The following is a description of a gene set: Genes having at least one occurrence of the highly conserved motif M139 AAAYWAACM in the regions spanning 4 kb centered on their transcription starting sites. This matches the FOXJ1 transcription factor binding site V$HFH4_01 (v7.4 TRANSFAC). Human Gene Set: AAAYWAACM_HFH4_01 Comprehensive identification of all functional elements encoded in the human genome is a fundamental need in biomedical research. Here, we present a comparative analysis of the human, mouse, rat and dog genomes to create a systematic catalogue of common regulatory motifs in promoters and 3' untranslated regions (3' UTRs). The promoter analysis yields 174 candidate motifs, including most previously known transcription-factor binding sites and 105 new motifs. The 3'-UTR analysis yields 106 motifs likely to be involved in post-transcriptional regulation. Nearly one-half are associated with microRNAs (miRNAs), leading to the discovery of many new miRNA genes and their likely target genes. Our results suggest that previous estimates of the number of human miRNA genes were low, and that miRNAs regulate at least 20% of human genes. The overall results provide a systematic view of gene regulation in the human, which will be refined as additional mammalian genomes become available. from publication Xie X, Lu J, Kulbokas EJ, Golub TR, Mootha V, Lindblad-Toh K, Lander ES, Kellis M (PMID 15735639) species: Homo sapiens, and this is the list of marker genes: NFE2L3 (NCBI Gene Id 9603), DMD, LGI1, HSPA2, ID2, TRIM8, P2RY10, NRK, PBX1, FOSB, MYLIP, GNL2, PALMD, MITF, LYST, NRXN3, IKZF3, NR4A3 (NCBI Gene Id 8013), CALD1, CIMAP1C, FEZF2, VASN, PMCH, GRIK3, LHX9, PPARGC1A, WNT5A, ID4, DTNA, NMNAT2, SLC44A1, EVL, STAP1, ZBTB37, TBCC, CNPPD1, HOXA10, OTX2, EIF4G1, CSMD3, KLF3, RFTN2, RAD21, CRY2, LINC00474, KLF3-AS1, NEDD4, AZI2 (NCBI Gene Id 64343), PAQR9, TJP1, SCRG1, H2AZ2, NTN1, HOXB4, FGF17, DUSP1, FUT11, CAST, TBX3, CNTNAP4, IQGAP3, C1QTNF3, SOX1, REPS2, PPP1CB, RETREG2, GRIK2, PAIP2, OMG, GATA6, PPP1R2B, MCC, GPR142, SNTB2, KRTAP17-1, NIPBL, UNC13D, ARHGAP30, ADAM11, IRS4, BRCA2, PHEX, SPATA18, ASIC1, GPR85, IMPDH1, INSM1, CPNE1 (copine 1), C7orf33, TPI1P2, SLC10A7, SLITRK2, BOK, HTR1B, CD68, ZHX2 (zinc fingers and homeoboxes 2), SLIT3, MYL1, ANGPT2, CRIM1, TCF4, TENT4B, EGR2, STAG2, DNAJB12, SDK2, CDK11B, STARD13, SIM1, STX5, DOCK3, MAP3K3, PRMT3, MIDEAS, NALCN, PURA, SMARCA2, SOX3, SCG3, CLN5, ATF7IP, NLGN3, RBM39, TSSK2, GSX1, TACSTD2, CADM2, CRH, CDK11A, ASXL1, NUDT11, ELOVL6 (NCBI Gene Id 79071), GRHL1, NAV3, FGF13, HMCN1 (NCBI Gene Id 83872), CREBRF, SNW1, HSF2, IDH1, LRRC3B, HOXB8, IRS1, C1QTNF6, HOXC12, GSC, ZMYND8, PRDM1, RGL2, FSTL1, RBFOX1, MARCHF5, CADM1, TP63, NEO1, HESX1, SYTL2, CTDSPL2, RALGPS2, KLHL3, NKD1, CHN2, BDH1 (3-hydroxybutyrate dehydrogenase 1), MGLL, CILK1, NREP, SCN2A (NCBI Gene Id 94312), PGM2 (phosphoglucomutase 2), CDH10, EFNA1, TLE3, CCN1, GRB7, CLVS1, HMGN2, HOXA11, KLF12, BCOR, WFDC9, KLF7, SNCAIP, CD36, NFIX, BCL6, FOXA2, PRX, SGK1, ARID1B, TSPAN13, NR2F2, FLRT3, RTL9, HOXA9, PDCD4, IRF4, MAFF, BCL11B, GOLGA1, ANKRD11, FOXP2, MEF2C, CPEB3, MBOAT2, FOXJ3, FBXL22, NCOA5, NKAIN2, ING3, TFEC, INMT (indolethylamine N-methyltransferase), MINDY1, CUTA, ITGA3, STX16, SYNE4, WFDC10A, RBP3, ITGBL1, BDNF, CYRIA (NCBI Gene Id 81553), MAML2, NDRG1, EPHB1, ATOH1, ANGPTL1, ZIC3, KCNH6, ARHGEF2, ATP2A2, ADAMTS14, CXXC5, NKAPP1, HOXA6, LIN37, NCAM1, GPX1, NSG2, ATOH8, EMSY, PIK3C2A, ARPP21, SIN3A (NCBI Gene Id 25942), UBE3A, KRTAP11-1, SEMA3A (semaphorin 3A), ENPP2, PLPP3, EPB41L3 (NCBI Gene Id 8730), TSHZ2, GFRA1, TCF7L2, PRR34, RPS6KB1, KCNQ5, BUB3, SPON1, REEP4, BMP7, MAB21L2, CNBP, SLC39A8, MSI2